The following is a description of a gene set: studied in species Homo sapiens Acute pancreatitis Human Gene Set: HP_ACUTE_PANCREATITIS A acute form of pancreatitis., and this is the list of marker genes: AGPAT2, APOE, IVD, LMNA, RNU7-1, NSMCE2, CYBC1, HMGCL, BSCL2, LPL